The following is a description of a gene set: electronically inferred by orthology from the curated human pathway species: Mus musculus This event has been computationally inferred from an event that has been demonstrated in another species.<p>The inference is based on the homology mapping from PANTHER. Briefly, reactions for which all involved PhysicalEntities (in input, output and catalyst) have a mapped orthologue/paralogue (for complexes at least 75% of components must have a mapping) are inferred to the other species. part of: Inositol phosphate metabolism Reactome Pathway: Synthesis of IP3 and IP4 in the cytosol, and this is the list of marker genes: Plch1, Itpk1, Inppl1, Plcd3, Plch2, Plcg2 (NCBI Gene Id 234779), Itpka, Itpkc, Plcb3, Inpp5b, Inpp5j, Plce1, Plcz1, Calm1, Ocrl